Given this list of marker genes Dnaja1, Cdc16, Wfs1, Anapc11, Rps27a, Ufc1, Trpm4, Smurf1, Rnf113a1, Fzr1, Med1 (NCBI Gene Id 19014), Btrc, Brap, Dysf, Trim13, Herpud1, Ubxn1 (UBX domain protein 1), Zc4h2, Plaa, Dcaf11, Med7, Klhl41, Cul9, Trib2, Asb5, Klhdc3, Pdzrn3, Jade2, Bag2, Ube2h, Ubb, Peli2, Cul3, Cdc34b, Trib3, Fem1c, Herc2, Sumo2, Fbxw7, Vcpip1, Dcaf17, Ctu2, Daw1, Rab40b, Uba3, Hif1a, D7Ertd443e, Rmnd5a, Rnf114, Mycbp2, Rbck1, Fancl, Ppara (NCBI Gene Id 399624), Med20 (NCBI Gene Id 78492), Hdac6, Trim24, Gsk3a, Tulp4, Cdk5, Uba7, Trim3, Prpf19, Aurkaip1, Daxx, Anapc4, Mgrn1 (mahogunin, ring finger 1), Nfe2l1, Asb2, Senp6, Bag5, D1Pas1, Fbxo33, Pink1, Lrrc41, Trim32, Med31, Ube2c, Marchf3, Asb15, Rag1, Ube2i, Hspa5, Neurl1b, Rnf146, Cblb, Stx1a, Klhl17, Trim30d, Amer1, Hamp2, E4f1, Herc3, Rela, Trpc4ap, Fbxo6, Dcun1d1, Klhl21, Rnf167, Usp4, Ogt, Cav1, Kcmf1, Hdac4, Ube2d2b, Anapc10, Peli1, Cdc23, Amfr, Pex2, Marchf7, Fanci, Ubd, Ahrr, Ube2v1, Med8, Rnf169, Skp1, Ndfip2, Abcb11, Fbxo22, Os9, Gnl3l, Zmiz1, Gm11690, Vps28, Herc4 (hect domain and RLD 4), Pias2, Pja2, Dtx4 (deltex 4, E3 ubiquitin ligase), Pias3, Atg5, Triml1, Ubr7, Rnf125, Trim30c, Btbd35f1, Skp2, Tnks2, Rnf26, Rnf166, Mocs3, Rpl11, Klhl24, Fem1b, Wwp1 (NCBI Gene Id 56840), Anapc13, Anapc7, Rusc1, Kbtbd2, Dtx1, Psen2, Pdcd6, Ube2t, Smad7, Nscme3l, Dcaf7, Nedd4l, Tbc1d7, Laptm5, Asb16, Fancm, Ube4a, Ube2l3, Rnf212 (NCBI Gene Id 671564), Cd300ld3, Fbxo9, Zfp91, Siah1b, Hecw2, Bcl2, Nsmce2, Klhl3, Asb14, Bard1, Dnaja3, Rnf20, Birc5, Fem1a (NCBI Gene Id 14154), Nae1, Klhl12, Pex10, Ercc8, Znrf4, Socs4, Tgfbr1, Ddrgk1, Ubxn2a, Klhl7, Wdsub1, Cish, Unkl, Mastl, Npm1, Fbxl3, Uba1, Atg3, Topors, Magel2, Sprtn, Inava, Rnf128, Uvssa, Cand2, Hltf, Smurf2, Sde2, Mkrn2, Bex4, Rnf6, Rc3h2, Rnf31 (ring finger protein 31), Mkrn1, Trim9, Cdc27, Nmi, Med10, Spsb3, Lrsam1, Ube2frt, Cry1, Pcmtd1, Hace1, Znrf2, Msl2, Tes3-ps, Rnf225, Fbxw15, Chp1, Tnfrsf1a, Dcaf8, Birc6, Hecw1, Traip, Derl1, Nfx1, Rnf217, Rnf13, Dcun1d2, Trim30b, Ube3b, Cbfb, Rangap1, Ube2e3, Fbxo28, Ddb1, Trim63, N4bp1, Anapc2, Ptpn22, Rnf7 (NCBI Gene Id 19823), Isg15, Spry2, Cdc26 (cell division cycle 26), Nedd8, Atg10, Traf3ip2, Cul7, Nxn (NCBI Gene Id 18230), Rnf43, Caml, Nt5c2 (5'-nucleotidase, cytosolic II), Rnf223, Map3k1, Zswim2, Siah2, Sqstm1, Hectd1, Rnf182, Med12, Trim68, Anapc1, Fbxl5, Phf23, Ubc, Ube2q1, Trim34a, Rnf181 (ring finger protein 181), Socs3, Lrrk2, Toporsl, Zfp598, Gsk3b, Cbl, Rffl, U2af2, Rnf122, Marchf5, Eipr1, Tnf, Zc3hc1, Rnf138, Rnf10, Anapc15, Ube2dnl2, Fbxw11, Prkce, Ube2u, Dnah12 (dynein, axonemal, heavy chain 12), Znrf1, Uhrf1, Epas1, Rnf38, Megf8, Spsb1, Dtx2, Kdm1a, Ppia, Fbxl22 (NCBI Gene Id 74165), Fbxo38 (NCBI Gene Id 107035), Pcnp, Psmd10, Pex12, Pnkp, Rad18, Trim39, Ranbp2, Hsp90aa1, Limk1 (NCBI Gene Id 547389, LIM domain kinase 1), Fbxo25, Usp44, Trim37, Neurl2, Med18, Asb17, Ube3c, Siah1a, Sash1, Pabpn1l, Mtor, Sh3rf3, Uba2, Kbtbd8, Wdr24, Rnf11, Trim71, Rasd2, Ubr5, Cul4b, Trim45, Fbxo43, Rnf186, Pja1, Anapc15-ps, Tollip, Birc2, Rnf144b, Lonrf2, Trim56, Shprh, Rnf144a, Elob, Klhdc1, Wdr77, Syvn1, Cul1, Rnf121, Socs1 (suppressor of cytokine signaling 1), Hmg20b, Marchf6 (membrane associated ring-CH-type finger 6), Trim52, Trim2, Park7, Ctu1 (cytosolic thiouridylase subunit 1), Asb10, Asb1, Arrdc3, Adgrb1, Mid2, Rchy1, Ubr1, Ccnf, Spop, Dcaf15, Ufl1, Klhl18, Socs5, Asb4, Bcl11a, Rnf2, Rnf139, Fbxo4, Ring1, Cop1, Trim62, Trib1, Senp2 (SUMO/sentrin specific peptidase 2), Lztr1, Ctnnb1, Cbx4, Gabarap, Tspo, Vps11, Ddx3x, Bex1, Ube2g1, Prkn, Hspa1b, Tnks, Marchf2, Trim8, Septin4, Irf2bp1, Fbxl2, Wdtc1, Trim5, Neurod2, Appbp2, Rnf112, Ube2s, Nod2, Kctd13, Fgfr3, Cul2, Trim21, Ltn1, Socs2, Ccnb1ip1, Tsg101, Rnf19a, Grb2, Ube2ql1, Ubox5, Trim7, Med27, Nosip, Fyn, Klhl9, Nlrc3, Hectd2, Ttc36, Dtx3l, Psen1, Ndfip1, Rnf26rt, Trim23, Gbp4 (NCBI Gene Id 17472), Klhl2, Ube2d4, Fbxl7, Klhl15, Ndp (Norrie disease (pseudoglioma) (human)), Tspyl5 (testis-specific protein, Y-encoded-like 5), Cdkn2a, Hmg20a, Egfr, Ube2d3, Rnf149, Fau, Cops9, Rnf185, Rlim, Ube2z, Ift80, Ambra1, Cand1, Huwe1, Cnot4, Pinx1, Ubac1, Marchf8, Nsmce3, Trim27, Fbxo2, Rab40c, Anapc5, Capn3, Ube2b, Zswim8, Ube2l6, Egr2, Med24, Prickle1, Trim26, Fbxl17, Sh3rf1, Ube2a, Trim6, Ubr2, Rnf216, Ubqln1, Rnf183, Fbxo7, Znrf3, Ube2q2l, Trim44, Rnf187, Rbx1-ps, Vps18, Fem1al, Fbxw8, Ube4b, Crbn, Bcl10, Fam107a, Wwp2, Rnf103, Rnf212b, Ccnc, Arrdc1, Chfr, Cul5, Asb7, Det1, Med23, Klhl25, Gtpbp4, Rps3, Asb6, Tnfaip3, Trim11, Trim28, Washc1, Socs7, Eloc, Neurl1a, Tm9sf5, Sae1, Marchf9, Fbxo31, Cdk5rap3, Hsp90ab1 (heat shock protein 90 alpha (cytosolic), class B member 1), Mib2, Ube2q2, Trim34b, Senp1, Neurl3, Rnf25, Akt1, Dtl, Pef1, Fbh1, Trim41 (NCBI Gene Id 97771), Commd1, Trim58, Wnk1, Mapk9, Ankib1, Fbxo30, Rnf40, Rpl23, Med6, Stub1, Mta1, Xiap, Ube2d1, Wwtr1, Itch, Marchf4, Dcaf10, Sharpin, Asb9, Trim59, Traf6, Gnl3, Dnajb2, Arrb2, Sirt7, Rnf111, Abl1, Rnf123, Tnfaip1, Hectd3, Ube2e1, Pias1 (NCBI Gene Id 72966), Tradd, Sphk1, Cdc20, Trim65, Usp9y, Socs6, Plk1, Rpgr, Ube2m, Vcp, Rnf138rt1, Uhrf2, Rnf133, Ubr4, Rnf113a2, Trip12, Keap1 (NCBI Gene Id 54157), Mdm4, Epm2a, Fbxo32 (F-box protein 32), Uba5, Cep63, Rnf135, Rc3h1, Rnf168, Minar1, Paxip1, Zzef1, Mylip, Wdr48 (NCBI Gene Id 67561), Fbxl12, Fbxo3, Wsb1, Nub1, Cdc34, Rnf130, Kbtbd7, Bfar, Anapc16, Kbtbd13, Rnf4, Rnf170, Rnf157, Rnf220, Rnf115, Pias4, Zmiz2, Fbxo10, Enc1, Tmem129, Ube2e2 (NCBI Gene Id 218793), Ankrd9, Nfe2l2 (nuclear factor, erythroid derived 2, like 2), Cdca3, Tcf25, Ube2g2, Trim35, Ube2dnl1, Mkrn3, G2e3 (NCBI Gene Id 320853), Ube2f, Rpl5, Rnf44, Klhl22, Ube2o, Lnx1, Rack1 (receptor for activated C kinase 1), Rnf5, Sirt1, Kbtbd6, Traf2, Rnf208, Vhl, Gps2, Trim12c, Nqo1, Sumo3, Trim33, Asb8 (NCBI Gene Id 78541), Ddb2, Ivns1abp, Klhl36, Ube3a, Dcaf12, Kctd6, Rbx1, Rnf41, Kctd9, Klhl8, Pttg1ip, Trim12a, Fbxo45, Ttc3, Trim25, Herc6, Birc7, Klhl40, Irf2bpl, Rfwd3, Fancf, Arel1, Hdac3, Prmt3, Ark2c, Gclc, Trim69, Med30, Rps2, Egf, Hdac8, Mul1, Ppp1r11, Klhl13, Nedd4, Lrr1, Pten, Ripk2, Sh3rf2, Asb18, Peli3, Asb12, Dcst1, Arrb1, Trim40, Atg7, Trim38, Rnf14, Cblc, Med21, Axin1, Marchf1, Fbxl21, Arnt, Rnf19b, Trim55, Fscb, Uba52, Bex3, Rnf213, Dcaf1, Rassf1, Ube3d, Uba1y (NCBI Gene Id 22202), Ubr3, Dcaf13, Wsb2, Kctd10, Rnf34, Cdc14b, Trim30a, Obi1, Frey1, Dcaf5, Rnf126, Aktip, Hspbp1, Mapk15, Dzip3, Trim17, Klhl10, Nhlrc3, Mad2l1, Fbxw5, Brca1, Uba6, Marchf11, Egr1, Ngf, Spsb4, Kctd21, Zfp451, Ube2r2, Rnf8 (ring finger protein 8), Wbp1l, Asb11, Cbll1, Aimp2, Dcun1d5, Traf7, Hamp, Cdk8, Klhl42, Ube2v2, Rps7, Bex2, Ifih1, Foxf2, Mib1, Sumo1, Ube2w, Rnf152, Ube2n, Prkcg, Mtbp (NCBI Gene Id 105837), Mad2l2, Gan, Ufm1, Klhl20, Med17, Nhlrc1, Rnf180, Cul4a, Arrdc4, Eya1, Cep78, Per2, Sox4, Dcun1d4, Mdm2, Spopl (NCBI Gene Id 99466), Bmi1, Ube2k, Arih2, Fbxo5 (NCBI Gene Id 97658), Med11, Arih1, Rassf5, Ube2srt, Fbxo11 (NCBI Gene Id 98072), Asb13, Dtx3, Rwdd3, Parp10, Rnf7l, Ppil2, Klhdc10, Ube2d2a, Mapk8 (NCBI Gene Id 26419), Svbp, Btbd1, Rnft1, Rbbp6, Rnf227, Ube2j2, Dcun1d3, Birc3, Dcaf6, Trim31, Dda1, Ube2j1, Asb3, Angpt1, Klhdc2, Ticam1, Trim47, Urm1 (NCBI Gene Id 68205), Rnf141, Kctd11, Fbxl15, Spsb2, here is a description of the gene set: A protein modification process in which one or more groups of a small protein, such as ubiquitin or a ubiquitin-like protein, are covalently attached to a target protein. studied in species Mus musculus Mouse Gene Set: GOBP_PROTEIN_MODIFICATION_BY_SMALL_PROTEIN_CONJUGATION